The following is a description of a gene set: from publication Martinez FO, Gordon S, Locati M, Mantovani A (PMID 17082649) Genes down-regulated in unstimulated monocytes versus macrophages incubated with CSF1 at day 7. Monocytes mature tom acrophages in the presence of the lineage determining cytokine M-CSF. They can be further polarized into M1 or M2 macrophages with distinct functional properties. We used microarrays to detail the global programme of gene expression underlying macrophage maturation and polarization and identified distinct classes of up-regulated genes during this process. studied in species Homo sapiens Human Gene Set: GSE5099_UNSTIM_VS_MCSF_TREATED_MONOCYTE_DAY7_DN, and this is the list of marker genes: EVA1C, TIMM17B, MED7, H1-10, ZBTB4, TNS3, ZMYM3, RHBDF2, CD14, NCKIPSD, ENO4, TTI1, GSDMA, PPM1L, PEX5, RNF112, NCF1, CCHCR1, RBM38, CBX6, COQ8B, KCTD20, CYP21A1P, FKBP1A, SRF, NOXO1, MYO19, NR4A1, SLC35E4, PCDHB6, HPS4, WDR81, SARM1, FCGRT, GMPPA, ADH1C, ADO, CYP24A1, DET1, APOE, CFAP206, SH3BGRL3, AMPD2, CTSW, KDM4D, ZFAND3, LAG3, TRPC3, SMPD2, NRSN2, TFF2, PLIN4, HELB, ZC3H12A, LRIG2, ZNF711, CNOT11, PKN1, GM2A, INSYN1, CFLAR, TAX1BP3, ARSI, PLEKHH1, FLNA, EIF4G1, KDM5D, HS3ST2, HS1BP3, BEX2, ETS1, POLR2A, TBC1D4, ATXN7L3B, GRINA, TFIP11, TSPAN14, RTKN2, HEXA, CAPN15, GMEB1, PRSS37, MRPL38, CHD3, RDH16, CCR10, BOP1, PML, AHSG, SNX32, KMT2D, ZCCHC12, HGS, E2F5, MZB1, PRDX4, NFASC, IFI30, AKAP4 (A-kinase anchoring protein 4), CHP2, GBA1, ALPG, TMEM191C, LRRC61, PREX2, INTS1, NKX2-3, ZNF710, DYNLL2, GPR108, PGF, TNIP2, LDHD (NCBI Gene Id 197257), FZD7, COL2A1, CGNL1, PRELID2, ACTRT3, SLX4, LY6H, CCDC85B, SMARCD2, CPSF4 (cleavage and polyadenylation specific factor 4), BCL2L12, TPRG1L, SMAD4 (NCBI Gene Id 4089), AVPR2, ORAI1, HLA-DRB1 (NCBI Gene Id 730415), MAN2B1, CHRNA4, KLHDC10, USP36, AP3M2, UBE2U, MFHAS1, MTHFSD, EDC4, MCU, ABHD12, S100B, PKP4, CS, MERTK, QNG1, ARIH2, TMEM121, EPN3 (NCBI Gene Id 55040), TBCEL, PPFIA4, CD99, KCNJ8, NAA60, RANBP6, GPR63, KLF6, GAA, PRPSAP1, CTLA4, BTBD9, TMEM176B, MMP17 (NCBI Gene Id 51403), SLPI, ATP6V0A1, GYPC, CRTC3, APOBR, LRP1, SLC18A1, SREBF1, SMPD4, MEN1, SOCS7, PLEC, PELP1, DERL3, MFSD13A, NHERF1, RCL1, ARF1, TRRAP (transformation/transcription domain associated protein), ADM, CYP4F22, DENND3, TUSC1, IER2, TRIM41, USP30, ALKBH6, SLN, OS9, PKDREJ, POP1, HDC, NUCB1, LY6D, CAD, ADAT1, USP14, ASPSCR1